The following is a description of a gene set: This event has been computationally inferred from an event that has been demonstrated in another species.<p>The inference is based on the homology mapping from PANTHER. Briefly, reactions for which all involved PhysicalEntities (in input, output and catalyst) have a mapped orthologue/paralogue (for complexes at least 75% of components must have a mapping) are inferred to the other species. Reactome Pathway: Purine salvage electronically inferred by orthology from the curated human pathway studied in species Mus musculus part of: Nucleotide salvage, and this is the list of marker genes: Adal, Pnp2, Ampd3, Ada, Dguok, Pnp, Dck, Gmpr